The following is a description of a gene set: Mouse Gene Set: GOBP_SNARE_COMPLEX_ASSEMBLY studied in species Mus musculus The aggregation, arrangement and bonding together of a set of components to form a SNARE complex, a protein complex involved in membrane fusion; a stable ternary complex consisting of a four-helix bundle, usually formed from one R-SNARE and three Q-SNAREs with an ionic layer sandwiched between hydrophobic layers., and this is the list of marker genes: Ankrd27, Vamp4, Stx1a, Uvrag, Snap25, Snca, Vamp3, Stxbp6, Vamp2, Cltrn, Stx4a, Trim9, Stxbp1, Vamp8, Prrt2, Septin8, Vamp1 (NCBI Gene Id 78668)